The following is a description of a gene set: species: Homo sapiens from publication Roessler S, Jia HL, Budhu A, Forgues M, Ye QH, Lee JS, Thorgeirsson SS, Sun Z, Tang ZY, Qin LX, Wang XW (PMID 21159642) Human Gene Set: ROESSLER_LIVER_CANCER_METASTASIS_UP Metastasis-related recurrence often occurs in hepatocellular carcinoma (HCC) patients who receive curative therapies. At present, it is challenging to identify patients with high risk of recurrence, which would warrant additional therapies. In this study, we sought to analyze a recently developed metastasis-related gene signature for its utility in predicting HCC survival, using 2 independent cohorts consisting of a total of 386 patients who received radical resection. Cohort 1 contained 247 predominantly HBV-positive cases analyzed with an Affymetrix platform, whereas cohort 2 contained 139 cases with mixed etiology analyzed with the NCI Oligo Set microarray platform. We employed a survival risk prediction algorithm with training, test, and independent cross-validation strategies and found that the gene signature is predictive of overall and disease-free survival. Importantly, risk was significantly predicted independently of clinical characteristics and microarray platform. In addition, survival prediction was successful in patients with early disease, such as small (<5 cm in diameter) and solitary tumors, and the signature predicted particularly well for early recurrence risk (<2 years), especially when combined with serum alpha fetoprotein or tumor staging. In conclusion, we have shown in 2 independent cohorts with mixed etiologies and ethnicity that the metastasis gene signature is a useful tool to predict HCC outcome, suggesting the general utility of this classifier. We recommend the use of this classifier as a molecular diagnostic test to assess the risk that an HCC patient will develop tumor relapse within 2 years after surgical resection, particularly for those with early-stage tumors and solitary presentation. Genes up-regulated in liver samples containing tumor thrombi in the major branches of the portal vein at surgery (PT) compared to those from metastasis-free HCC patients (PN) at the time of surgery and at follow-up., and this is the list of marker genes: KMT5B, YES1, SPOCK3, ASPH, FEN1, DTYMK, PMAIP1, EPB42, GTF2H1, ATF2, GCNT2, ENO3, RAB8A, SLC20A2, SART1, KCNQ1, CSF3R, MATK, CDH13, CALCOCO2, CES1, TGOLN2, COPA, RAD50, STOML1, CLCN7, VPS41, MVK, CD37, USP12, AP1S1, GPD2, LTF, LPL, KHK, HSD3B1, SPTBN2, MAP3K6, CHEK1, GCFC2, RAB28, NEMP1, HMMR, RPA2, PLD2, CTRB1, RGS20, CDS1, FANCC, ITGA9, LRP6, NR1D2, UNC119B, FZD2, BASP1, VAMP3, ALDH3B1, NUP205, CHGB, LIMK1, RFC5, IRF2, CD247, IL2RB, RHAG, SLTM, PLA2G6, HOXB13 (homeobox B13), CCR3, CENPE, GTF2H4, SERPINB6, GCLC, LY6E, ABL2, MDFI, EMD, CYTH3 (cytohesin 3), ADGRL1, GABRE, TSHZ1, TRAP1, SPP1, JOSD1, STUB1, ALDH3B2, ZNF646, AKR1C4, PRR3, MMP9, RFTN1, G3BP2, ENO2, SELENBP1, RAB3A, GUCA2B, NFKB1, PITX2, MYD88, PYGB, ADD2, GYS1, PDK1, NCAPD3, COL4A5, FUT8